Given this list of marker genes HMBS, TONSL, GDF6, MEOX1, RASA1, GDF3, HTRA1, DKK1, here is a description of the gene set: An unpleasant sensation characterized by physical discomfort (such as pricking, throbbing, or aching) localized to the neck. Human Gene Set: HP_NECK_PAIN Neck pain studied in species Homo sapiens